The following is a description of a gene set: Mouse Gene Set: GOBP_NEGATIVE_REGULATION_OF_FATTY_ACID_TRANSPORT Any process that stops, prevents, or reduces the frequency, rate or extent of fatty acid transport. studied in species Mus musculus, and this is the list of marker genes: Acacb, Atp5pf, Akt2, Acsl4, Thbs1, Fis1, Pla2r1, Akt1, Irs2, Agtr2, Hrh2